Given this list of marker genes SRD5A2 (NCBI Gene Id 6716), FZD2 (frizzled class receptor 2), EIF2S3, HES2, CCL2, PMP22, MSLN, SLC16A3, IL1R2, RALY, EMB, CDH11, CCL7, here is a description of the gene set: Hox genes encode transcription factors that control spatial patterning during embryogenesis. To date, downstream targets of Hox genes have proven difficult to identify. Here, we describe studies designed to identify target genes under the control of the murine transcription factor Hoxc8. We used a mouse 16,463 gene oligonucleotide microarray to identify mRNAs whose expression was altered by the overexpression of Hoxc8 in C57BL/6J mouse embryo fibroblasts (MEF) in cell culture (in vitro). We identified a total of genes whose expression was changed by 2-fold or greater: genes were up-regulated, and genes were down-regulated. The majority of genes encoded proteins involved in critical biological processes, such as cell adhesion, migration, metabolism, apoptosis, and tumorigenesis. Two genes showed high levels of regulation: (i) secreted phosphoprotein 1 (Spp1), also known as osteopontin (OPN), was down-regulated 4.8-fold, and (ii) frizzled homolog 2 (Drosophila) (Fzd2) was up-regulated 4.4-fold. Chromatin immunoprecipitation (ChIP) analysis confirmed the direct interaction between the OPN promoter and Hoxc8 protein in vivo, supporting the view that OPN is a direct transcriptional target of Hoxc8. studied in species Mus musculus Genes up-regulated in MEF cells (embryonic fibroblasts) by overexpression of HOXC8. Human Gene Set: LEI_HOXC8_TARGETS_UP from publication Lei H, Wang H, Juan AH, Ruddle FH (PMID 15699330)